The following is a description of a gene set: Genes predicted to be targets of miRBase v22 microRNA mmu_miR_6384 in miRDB v6.0 with MirTarget v4 prediction scores > 80 (high confidence targets). species: Mus musculus Mouse Gene Set: MIR_6384 from publication Chen Y, Wang X (PMID 31504780), and this is the list of marker genes: Mtcl1, Lsamp, Ccdc126, Traf3, Slc7a13, Zfp975, Hibadh, Grm1, Naa15, Map2, Phox2b, Cd59a, Cpeb3, Dcaf10, Eef2kmt, Mtarc1 (mitochondrial amidoxime reducing component 1), Pld5, Larp4, Plxna2, Cfap141, Timp2, Coch, Irgq, Gml2, Txndc17, Cdh7, Zfp629, Ptges3, Neu3, Mfsd14b (NCBI Gene Id 66631), Zfp609, Ccl22, Erap1, Ddx6, Chmp5, Stox2, Stk39, Slc41a2, Arap3, Abca8b, Tnrc6b, Nhsl2, Rhod, Igfbp2, Sec16a, Zik1, Prkca, Birc6, Gmps, Baz1a, Zfp827, Ctdp1, Bicd1 (BICD cargo adaptor 1), Ago4, Gucy1a2, Myo5c, Ahcyl2, Mars2, Cpeb4, Trim33, Notch2, Runx1t1, Peak1, Pou3f2, Map3k20, Rhoq, Pnp, Zfp846, E2f5, Iqgap1, Rbl1, Pdpn, Eef1a1, Iba57, Anxa1, Scoc, Zfp236, Ntng1, Abhd15, 1810030O07Rik (NCBI Gene Id 69155), Cramp1, Phf14, Prkaa2, Cd28, Ttc32, Dnajb12, Kpnb1, Fn1, Gml, Pdzrn4, Slain2, Ablim1, Ino80d, Reps2, Marchf6, Hoxa9, Mzt1, Diablo, Thbs3, Jun, Foxn2, Atp1a2, Pcnt, Ist1, Cmtr2, Calml3, Slc16a2, Zfp235, Ppargc1a, Aak1, Rassf8, Prxl2a, Cep76, Samd4, Zfp322a (NCBI Gene Id 218100), Cacna1d, Phactr2, Cetn1, Dock4, Ubn2, Lrrtm4, Ercc3, Zkscan8, Naa30, Klhl24, Rab30, Cul3, Dgkg, Ecrg4, Keg1, Cstf2, Chic1, Hoxb7, Sp4, Vwa5a, Ttbk2, Crybg3, Ttpa, Ccnyl1, Dr1, Cers4, Map3k13, Vapb, Magi3, Greb1, B3gnt5, Sema3g, Lsm11, Rnf150, Picalm, Myof, Amer2 (APC membrane recruitment 2), Crem, Papola, Epha5, Tnrc6a, Gria2, Zfp106, Zfhx3, Xpc, Zfp287, Tcta, Golph3, Fhip1b, Cd93, Zfp831, Fbxo45, Zfp874b, Tsc1, Rsad2, Pnpt1, Asb5, Slc17a4, Trim39, Nr3c1, Insm1, Srsf4, Plpp5, N4bp1, Col15a1, Tyw5, Hyal6, Snx18, Ythdf2, Clock, Rufy1, Fst, Kdm2a, Khsrp, Cd59b